The following is a description of a gene set: Human Gene Set: GOMF_PHOSPHATIDYLINOSITOL_3_KINASE_REGULATORY_SUBUNIT_BINDING Binding to a regulatory subunit of phosphatidylinositol 3-kinase. The regulatory subunit associates with the catalytic subunit to regulate both its activity and subcellular location. species: Homo sapiens, and this is the list of marker genes: CD2AP, PIK3R2, NLRC3, PTPN13, CBL, PIK3AP1, FAM83A (NCBI Gene Id 84985), FBXL2, FAM83B, DAB2IP, PIK3R1